The following is a description of a gene set: An mRNA destabilization process in which one or more RNA-binding proteins associate with the 3'-untranslated region (UTR) of an mRNA. Mouse Gene Set: GOBP_3_UTR_MEDIATED_MRNA_DESTABILIZATION studied in species Mus musculus, and this is the list of marker genes: Trim71, Zfp36l1, Dnd1 (DND microRNA-mediated repression inhibitor 1), Tardbp (TAR DNA binding protein), Zfp36, Khsrp, Rc3h1, Hnrnpd, Zc3h12d, Plekhn1, Rbm24, Dhx36, Zfp36l2, Cpeb3, Mov10, Zc3h12a, Upf1